Given this list of marker genes RGS19, PPP1R14B, AQR, ACTR6, PLBD1, FANCF, PHTF2, SERF2 (NCBI Gene Id 88287), IGFBP4, SRSF9, NLRX1, LRRC59, RARS2, SYNPO2, PTGES, FAR1, MECR, FOSL2, SPC25, TRIAP1, MAVS (NCBI Gene Id 78993), CX3CR1, EED, PSTPIP2, EXOSC10, SLC35A1, STARD7, THBS1, FN1, NCBP1, DRG1, MRPS12, FDPS, BLTP3B, KCTD14, TRAF3IP2, SLC35A4, SLCO3A1, TLR2, SLC41A2, ABCB4, LIG3, MCUB, SLC40A1, SHPRH, FASN, RAI14, WDR83OS, LGALS12, SFXN3 (sideroflexin 3), CYB5R1, HSP90B1, VBP1, DCX, MPHOSPH6, CLNK, DNAJB6, RAP1GDS1, TARBP2, BTBD1, COX6C, SLC25A10 (solute carrier family 25 member 10), CENPC, KDELR1 (NCBI Gene Id 10945), TMEM38B, TRMT2A, RNF26, NF2, MYOG, GRK2, GRK6, API5, MFSD14A, EIF4E, STT3A, MANF, HEXB, POLDIP2, PWP1, ARTN, ACTL6A, RDH10, CIAO2A, SLC22A4, RRP9, COX8A, ZC3H8, CNIH1, KIF13A, UQCC2, ACLY, CDC25A, ARL1, IL1RAP, FCER1G, PAFAH2, NIBAN2, AP2S1, NCBP2 (NCBI Gene Id 22916), SIMC1, DDX24, OTUD6B, RNASEK (ribonuclease K), ACSS2, DGKZ, XYLT2, SRFBP1, SDHC, TTC7B, TAF13, MMP12, SOCS1, APOC2, B3GALNT2, EGLN3, GARS1, FBXO15, EIF4G2, MRPS17, EMC7, HSD17B7, BCKDHB, DDB1, EIF1AY, ERO1A, MAT2A, RIDA, UTP20, SNX18, BOP1, QNG1, PDE8A, IL36G, NUP160, FDFT1 (farnesyl-diphosphate farnesyltransferase 1), SMC4, AP5M1, COPB1, GAS2, GTF2E2, MTDH, LCP2, FAM8A1, CTBP2, TMA7, MMACHC (NCBI Gene Id 25974), PRKACA, POLR3D, IPO9, PEX12, TP53RK, MYO1B, PSMG1, SELENOS, IMPDH2, RAD50, LUC7L, CPSF1, ARHGDIA, HEATR6, SLAIN2, SEPHS2, KCNA3, PHPT1, RPS3, PER2, PRPF40B, KRTAP15-1, MTX1, PDF, CDR2, IAH1, ULK2, SMAD7, ESRRA, TRMT10C, SEPTIN7, NUP37, UBE2W, HCK, TRIM27, MMUT, PNO1, RCC1L, ATP6V0B, PRMT3, RPL37A, NPM1, NOA1, HSP90AA1, RHOT1, KIF3C, CTU1, PSMG3, SRSF6, CCDC107, BABAM1, PPP5C, ANGPTL2, PSMD5, here is a description of the gene set: from publication Amit I, Garber M, Chevrier N, Leite AP, Donner Y, Eisenhaure T, Guttman M, Grenier JK, Li W, Zuk O, Schubert LA, Birditt B, Shay T, Goren A, Zhang X, Smith Z, Deering R, McDonald RC, Cabili M, Bernstein BE, Rinn JL, Meissner A, Root DE, Hacohen N, Regev A (PMID 19729616) studied in species Homo sapiens mouse primary BMDCs were stimulated with tlr ligands and gene expression changes were profiled on Affymetrix arrays Genes down-regulated in comparison of dendritic cells (DC) stimulated with poly(I:C) (TLR3 agonist) at 12 h versus DC cells stimulated with Gardiquimod (TLR7 agonist) at 12 h. Human Gene Set: GSE17721_POLYIC_VS_GARDIQUIMOD_12H_BMDC_DN